Given this list of marker genes CYLC2, ZNF559, ZNF550, CAMK4, KCNK17, PLEKHA5, AGAP1, PTHLH, ZNF99 (NCBI Gene Id 7652), FMC1-LUC7L2, MFN2, ZNF28, RBBP5, SH3PXD2A, GNB4, SLC23A3, HJURP, CCDC178, TACC1, FADS1, IL7, MRPS23, PVALB (NCBI Gene Id 5816), ANAPC11, SLC7A8, ZNF705EP, RWDD1, ZNF559-ZNF177, RAB36, MTHFD1L, NSG2, KCNE4, SYT2, ZNF117 (zinc finger protein 117), ZNF195, DNAJB5, KCNN3, WDR82, TPD52L3, CREB5, SH3RF3, SRGAP1, TMEM132B, NADK, RAD51, HOXA13, LUC7L2, MAPRE1, ZNF763, C7orf25, RIPK1, TNFRSF21, KLHL1, ZNF490, NR3C2, SLC25A34, GPATCH2, ZNF124, SLC35C2, GNAS, KCNH6, ZFP90, MED22, TSHZ2, ITPRIPL2, EPHA10, MAP4K5 (NCBI Gene Id 11183), LEAP2, SPATS2, ZNF468, NDST1, DMRT2, GIPR, SH3TC2, LRR1, FBXO45, SPACA9, CADM2, SLC5A9 (NCBI Gene Id 200010), CARD8, SIRT6, ZNF257, ZNF732, MEAF6, SIKE1, KLHL29, NR1D2, TUFT1, ASIC1, ZNF426, DAG1, PRKCG, MAP3K2 (mitogen-activated protein kinase kinase kinase 2), LRPAP1, FAS, RGS16, ETS1 (NCBI Gene Id 2113), ZNF676, ZNF107, CRISP1, F8, PDCL3, DLGAP5, KCNG4, CD28 (CD28 molecule), MAP3K3, MINDY2, TIMM8A, MARCHF9, GPD2, SSTR3, TMEM33, RRP7A, KCNA4, BDKRB2, IRGQ, BOC, F7, SPEG, KNOP1, VAPB, PTPRB (protein tyrosine phosphatase receptor type B), CHRNA5, SIRPA, MPP4, TMEM200A, ZFAND3, RAB29, SMIM20, ARMH3, CD24, PHF3, CEACAM6, MECP2, SLIT2 (NCBI Gene Id 9353), CPD, PDXDC1, ZNF544, GPR132, SPPL3, PPM1M, BBX, ADAMTSL1, POU2AF1, ITGA8, ZNF208, SMCR8, TFDP2, ZNF845, LYRM9, NUP210, ZNF493, ZNF850, SHISA6, here is a description of the gene set: Human Gene Set: MIR766_3P from publication Chen Y, Wang X (PMID 31504780) species: Homo sapiens Genes predicted to be targets of miRBase v22 microRNA hsa-miR-766-3p in miRDB v6.0 with MirTarget v4 prediction scores > 80 (high confidence targets).